The following is a description of a gene set: Any process that results in a change in state or activity of a cell (in terms of movement, secretion, enzyme production, gene expression, etc.) as a result of a biotic stimulus, a stimulus caused or produced by a living organism. Mouse Gene Set: GOBP_CELLULAR_RESPONSE_TO_BIOTIC_STIMULUS species: Mus musculus, and this is the list of marker genes: Klrk1 (killer cell lectin-like receptor subfamily K, member 1), Efnb2, Gbp10, Mir598, Irak3, Tmco1, Ifng, Mir146b, Mir24-1, Cd6, Ppard, Ass1, Slc12a2, Casp1, Cxcl15, Mus81, Mir223 (microRNA 223), Cdc73, Cdk19, Cdk4, Mir194-1, Spon2, Bcr, Sgms1, Clec7a, Mir29b-1, Ednrb, Acod1 (NCBI Gene Id 16365), Mapk14, Serpine1, Mif, Syk, Hadhb (hydroxyacyl-CoA dehydrogenase trifunctional multienzyme complex subunit beta), Stap1, Mir199a-1, Mir467d, Defa40, Il1b, Cr2, Mtdh, Csf3, Ptpn6, Trem2, Aicda, Mir10a, Gbp2b, Ccl2, Rela, Myd88, Irgm1, Mmp8, Trib1, Defa21, Nfkbiz, Tlr9, Mir293 (microRNA 293), Cxcl2, Tirap, Cd180, Defa20, Mir26b, Il36rn, Mir205, Il1f10, Mir350, Mir409, Nr1i2, Mir511, Trim5, Camp, Mir431, Mapk8, Mir345, Cda, Src (NCBI Gene Id 99351), Ptpn22, Defa28 (NCBI Gene Id 626682), Eme1, Cd55b (NCBI Gene Id 98313), Mir200c, Nr1h3, Kmo, Tnip2, Defa42, Mir27a, Pdcd4, Nfkbil1, Pdcd1lg2, Defa3, Mir433, Tigar, Mir199a-2, Defa31, Gsk3b, Mir147, Defa34, Mir23b, Ang4, Mir494, Nr1h4, Tnfrsf1b, Nod2, Prdx2 (peroxiredoxin 2), Defa24, Defa30, Cebpe, Mir15a, Mir98, Pabpn1, Ticam2, Axl, Rara, Sirpa, Tlr2 (toll-like receptor 2), Tlr6, Casp7, Ins2, Defa5, Mrc1, Mir210, Ccr5, Ptpn11, Ppp1r15b, Il36b, Notch1, Akap8 (NCBI Gene Id 67462), Tnfaip3, Map2k7 (mitogen-activated protein kinase kinase 7), Bpi, Ptgs2, Tnip3, Defa26, Mir184, Mapk3, Wfs1, Irak4, Shpk, Eif2ak3, Esr2, Bcl2l11, Ddit3, Il10, Mir181b-2, Mir24-2, Notch2, Cxcl16, Mir16-2, Jak2, Mir29a, Mir486, Ly96, Mir500, Stat1, Defa38 (defensin, alpha, 38), Txnip, Ripk2, Mir125a, Irak1, Sash1, Smc1a, Defa25, Nos3, Ticam1, Btk, Gbp3, Il36a, Slc7a5, Ephb2, Sbno2, Rhoa, Mir7-2, Pde4b, Nlrp3, Nos2 (NCBI Gene Id 18126), Mir26a-1, Arid5a, Tspo, Prkce, Mir146, Gfer, Vim, Hspa5, Wnt5a, Cxcl9, Mirlet7g, Lbp, Mir217 (microRNA 217), Trim12c, Hmgcs2, Cxcl13, Cd86, Ghsr (growth hormone secretagogue receptor), Il12a, Ccl28, Nfkbib, Cyrib, Mir383, Tnfsf4, Rbm14, Selenos, Il36g, Mir29b-2, Mef2c, Il18, Spi1, Zmpste24, Trim30d, Cd55, Fzd5, Chmp5, Mir30b, Akt1, Capn2, Tnf, Ahr (NCBI Gene Id 193333), Ltf, Bmp6, Ly86, Mir26a-2, Plcg2, Nfkb1, Fcgr4, Tlr1, Mirlet7a-2, Zc3h12a, Atg10, Igfbpl1, Zfp36, Mir672, Ctr9, Cd274, Il1a, Mir224, Ccdc47, Trp53, Bcl10, Fbh1, Ogt, Mir484 (NCBI Gene Id 723916), Gfi1, Cd36, Cd14, Ctsg, Ncl, Scarb1, Trim30b (NCBI Gene Id 244183), Cd68, Mir7b, Abl1, Bid, Dab2ip, Abca1, Slx4, Defa2, Gbp6, Cxcl5, Defa35, Raet1d, Mir181c, Gbp5, Il12b, Defa41, Mapk1, Malt1, Defa37, Mir142, Ldoc1, Epsti1, Pde4d, Irgm2, Adam9, Mir150 (microRNA 150), Defa22, Cd300lb, Cx3cl1 (C-X3-C motif chemokine ligand 1), Lyn, Tnip1, Cx3cr1, Irak2, Mir342, Trim30c, Mir155, Defb25, Mir194-2, Irf3 (NCBI Gene Id 54131), Il6, Il2, Mir30c-1, Defa23, Scimp, Abcb1a, Defa17, Prpf8, Nfkbia, Defa29, Hmgb1, Plscr3, Trim55, Paf1, Tlr4, Plaa (NCBI Gene Id 52374), Havcr2 (hepatitis A virus cellular receptor 2), AY761185, Plscr1, Hmgb2, Mir202, Mir425, Trim12a, Mir139, Ankrd1, Tut4, Mir181a-2, Trim30a, Irf8, Ptafr, Pycard, Adamts13, Pde2a, Mir501, Cebpb, Defa39, Star, Mir181a-1, Mir193a, Pf4, Nr1d1, Plscr4, Map2k3, Mir30d, Mir7-1, Plscr2, Tifab, Ccl27a, Cactin, Gch1, Trim41, Litaf, Mir182, Gata1, Mir140, Mir107, Cxcl10, Mir30c-2, Nuggc, Xbp1, B2m, Ppbp, Gbp2, Tbxa2r, Nr2c2, Defb21, Mir381 (NCBI Gene Id 723935), Cfh, Cd84, Fcgr2b, Igtp, Upf1, Gstp1, Traf6, Git1, Ppm1e, Cmpk2, Mir323, Cd80, Prkca, Lilrb4a